The following is a description of a gene set: Delay in cutaneous immune reaction to specific antigens mediated not by antibodies but by cells. The delayed hypersensitivity test is an immune function test measuring the presence of activated T cells that recognize a specific antigen and is performed by injecting a small amount of the antigen into the skin. The area of the injection is examined 48-72 hours thereafter. Human Gene Set: HP_ABNORMAL_DELAYED_HYPERSENSITIVITY_SKIN_TEST Abnormal delayed hypersensitivity skin test studied in species Homo sapiens, and this is the list of marker genes: FASLG, CIITA, WAS, EPG5, JAK3, RAB27A, CASP10, FAS, NSMCE3